The following is a description of a gene set: Human Gene Set: GSE17301_IFNA2_VS_IFNA5_STIM_ACD3_ACD28_ACT_CD8_TCELL_UP from publication Hervas-Stubbs S, Riezu-Boj JI, Gonzalez I, Mancheño U, Dubrot J, Azpilicueta A, Gabari I, Palazon A, Aranguren A, Ruiz J, Prieto J, Larrea E, Melero I (PMID 21108462) Genes up-regulated in CD8 T cells stimulated by IFNA2 versus CD8 T cells stimulated by IFNA5 and activated by anti-CD3 and anti-CD28. species: Homo sapiens IFN alpha mediated gene expression pattern. The effect of IFN alpha on human CD8 T cells responding to antigen (signal 1) and costimulatory signals (signal 2) provided by beads coated with anti-CD3 and anti-CD28 mAbs. This analysis examined the effects of IFN alpha on human CD8 T cells responding to antigen (signal 1) and costimulatory signals (signal 2) provided by beads coated with anti-CD3 and anti-CD28 mAbs. Magnetically sorted untouched CD8+CD45R0- T cells from three different donors were unstimulated or stimulated with IFNa2b or with anti-CD3/CD28 Beads alone or along with IFNa2b or IFNa5 for 48 hours. Individual mRNA samples were analyzed using HG-U133A 2.0 array gene chips., and this is the list of marker genes: RNF31, NDST2, JMJD1C, BAG4, ZNF274, TRMO, IGF2BP3, HSD17B12, AGTPBP1, WNT10B, IMPACT, SLC35A5, CRYL1, TRAF3IP3, NINJ1, HOMER1, PRSS16, MACO1, TOM1L1, SPOCK2, GPR18, PITPNM1, ACTN1, SPRY4, TMEM50A, HERC1, RGS10, HCLS1, RAB3GAP1, CARMIL1, LPIN2, MFSD1, RAP2C (NCBI Gene Id 57826), PLEKHA1, P2RY10, NOSIP, TBL1X, AHCTF1, FAM89B, DDIT3, SRGAP3 (NCBI Gene Id 9901), ARID5B, SCYL3, RREB1, MAST4, ETNK1, ZNF215, TMEM14A (transmembrane protein 14A), CRISPLD2, NLRP1, ICA1, PIP4K2C, PIBF1, FBXO21, EXOC2, TBC1D15, CSK, MFN1, IFITM2, SUN2, PIM2, CCR9 (C-C motif chemokine receptor 9), APMAP, SP100, BTN2A1, HSPA1L, KRT18, ENGASE, BMAL1, CTR9, RERE, EHBP1L1, NDRG3, ATP8A1, EGR1, EPHA1, AGRN (agrin), IL6ST, KIF3C, SPON1, FOXJ2, TCF25, COQ2, RWDD3 (RWD domain containing 3), MOAP1, MARCHF3, IER2, TRIP11, OSMR, NDE1, PNN, ACVR1B, TNIP1, IER3, ADAM23, TRIB2, TPK1, PLXDC1, SAMSN1, RASGRP2, AFTPH, LRIF1, SOS2, IL32, GCH1, DDX60, SLC31A1 (solute carrier family 31 member 1), PDCD4, TMEM43, ADPGK, ZFYVE16, TMEM9B, DENND4A, N6AMT1 (N-6 adenine-specific DNA methyltransferase 1), NIBAN1, CNOT8, UBASH3A, CAST, ZSWIM8, CAMK4, ARFRP1, IRF3, FAM174B, LTA, ETHE1, ESS2, FBXO34, BACH2, SEC62, CCNT2, GSPT2, RAB29, HIVEP1, TXNDC15, IL4R, RCHY1, ABR, CACNA2D2, SAP30L-AS1, ZBTB18, RUNX1, CD247, RASA1, JUNB, HECA, SPRY2, MCL1, WDR37, PCID2, PRRC2B, MTCP1 (mature T cell proliferation 1), FRAT1, MAP3K4, CLDN1, HMCES, ZNF234, CDK11A, NBR1, C21orf91, N4BP2L1, TNFRSF25, SQOR, IFNA6, PIK3IP1, CCR7, RABEPK, AIP, WAPL, BIN1, CREBL2, CDS2, MPPE1, MYOM2, WWC3, IRF2, PASK, ARPC5, EMC3, FCGRT, COX4I1, NR4A2 (NCBI Gene Id 4929), SMIM27, PRRC2C, FBXO11, GPRASP1, GVINP1, POR (NCBI Gene Id 96440), FBXO38, ACTR3, MSN, PPP1R2, ARL6IP5, FLT3LG, ZNF562, ZCCHC4, STAT5B, FIG4, TLE2